The following is a description of a gene set: Mouse Gene Set: GOBP_REGULATION_OF_ALDOSTERONE_METABOLIC_PROCESS Any process that modulates the frequency, rate or extent of the chemical reactions and pathways involving aldosterone. studied in species Mus musculus, and this is the list of marker genes: Dab2, Wnt4, Bmp2, Bmp6, Bmp5, Dkk3, Clcn2, Rest, Kcnma1